The following is a description of a gene set: Human Gene Set: GOMF_MINOR_GROOVE_OF_ADENINE_THYMINE_RICH_DNA_BINDING Binding to a DNA structure formed by the minor groove of adenine-thymine-rich DNA regions. Examples of proteins having this function are AT-rich interaction domain (ARID)-containing proteins. studied in species Homo sapiens, and this is the list of marker genes: HMGA1, MAPT (NCBI Gene Id 8152), HAND2, MEF2C, H1-0, KMT2A, HNRNPD, LIN54, HMGA2